Given this list of marker genes Hadha, here is a description of the gene set: Reactome Pathway: Beta oxidation of myristoyl-CoA to lauroyl-CoA species: Mus musculus electronically inferred by orthology from the curated human pathway part of: mitochondrial fatty acid beta-oxidation of saturated fatty acids This event has been computationally inferred from an event that has been demonstrated in another species.<p>The inference is based on the homology mapping from PANTHER. Briefly, reactions for which all involved PhysicalEntities (in input, output and catalyst) have a mapped orthologue/paralogue (for complexes at least 75% of components must have a mapping) are inferred to the other species.